Given this list of marker genes PAX5 (paired box 5), CHD7 (NCBI Gene Id 780907), FAM133A, PIF1, HIKESHI, MAGEC1, SLC35F2, MTURN, STK24, TMEM126A, ZDHHC14, NAPRT, PRDM5, SEPTIN9, TAF1D, ICAM4, MOB3A, ARHGEF12, MRPS31, DPP7, TKT, DHPS, RPS2, NPAT, TLR10, MSANTD4, CHD2, LETMD1, RHOA, SLC16A6, ANKRD49 (NCBI Gene Id 54851), NMRAL1 (NmrA like redox sensor 1), OAS3, SPIN3, SLC35D2, APOL1, GPALPP1, ZBTB26, POLR1D, CLTA, ARHGAP42, EIF3J-DT, ISL2, TMEM123, RHOBTB3, here is a description of the gene set: from publication Zhan F, Huang Y, Colla S, Stewart JP, Hanamura I, Gupta S, Epstein J, Yaccoby S, Sawyer J, Burington B, Anaissie E, Hollmig K, Pineda-Roman M, Tricot G, van Rhee F, Walker R, Zangari M, Crowley J, Barlogie B, Shaughnessy JD Jr (PMID 16728703) Top 50 down-regulated genes in cluster MS of multiple myeloma samples with characteristic expression spike of WHSC1. Human Gene Set: ZHAN_MULTIPLE_MYELOMA_MS_DN studied in species Homo sapiens To better define the molecular basis of multiple myeloma (MM), we performed unsupervised hierarchic clustering of mRNA expression profiles in CD138-enriched plasma cells from 414 newly diagnosed patients who went on to receive high-dose therapy and tandem stem cell transplants. Seven disease subtypes were validated that were strongly influenced by known genetic lesions, such as c-MAF- and MAFB-, CCND1- and CCND3-, and MMSET-activating translocations and hyperdiploidy. Indicative of the deregulation of common pathways by gene orthologs, common gene signatures were observed in cases with c-MAF and MAFB activation and CCND1 and CCND3 activation, the latter consisting of 2 subgroups, one characterized by expression of the early B-cell markers CD20 and PAX5. A low incidence of focal bone disease distinguished one and increased expression of proliferation-associated genes of another novel subgroup. Comprising varying fractions of each of the other 6 subgroups, the proliferation subgroup dominated at relapse, suggesting that this signature is linked to disease progression. Proliferation and MMSET-spike groups were characterized by significant overexpression of genes mapping to chromosome 1q, and both exhibited a poor prognosis relative to the other groups. A subset of cases with a predominating myeloid gene expression signature, excluded from the profiling analyses, had more favorable baseline characteristics and superior prognosis to those lacking this signature.